The following is a description of a gene set: species: Homo sapiens TGFBR3 PTM regulation Human Gene Set: REACTOME_TGFBR3_PTM_REGULATION, and this is the list of marker genes: PSEN1, PSENEN, TIMP1, MMP16, TGFBR3, PSEN2, TIMP2, MMP14, NCSTN, APH1A, APH1B